Given this list of marker genes Zpr1, Esrrb, Cops2, Igf1, Grn, Dicer1, Acvr1c, here is a description of the gene set: studied in species Mus musculus The proliferation of cells in the trophectoderm. Mouse Gene Set: GOBP_TROPHECTODERMAL_CELL_PROLIFERATION